Given this list of marker genes ADRA2C, GUCY2F, EEF1B2, EIF2S3, SAMHD1 (SAM and HD domain containing deoxynucleoside triphosphate triphosphohydrolase 1), RABGEF1, ARL17B, MON1A, TIAM1, GFM1, DEF6, EHD1, DIRAS1, SEPHS1, RASGRP1 (NCBI Gene Id 10125), RIT1, EIF2B2, TUBE1, TUBA3C, RAB17, MOCS1, ARL13A, PSD2, TUBB4B, NGB, DNAJC27, P2RY12, GNA13, ECT2, TUBA1C, PIP4K2B, RIC1, GUCY2C, CYTH1, TUBB2A, GIMAP1, PRKG2, ARL3 (NCBI Gene Id 403), TBC1D10A, MCF2L, ARHGEF10, PDE11A, CCDC88C, ABR, RAB1C, EHD3, VAV3, RASL10A, PDE6H, IFT27 (intraflagellar transport 27), GUCY2D, TRIM23, EHD4, ARHGEF37, SEPTIN9, IFT22, PLEKHG5, GRIPAP1, DENND5B, TIAM2, ARHGEF18, RAB6B, RAB37, SEPTIN5, LRRK2, RAB3IL1, ARHGEF6, RAPGEF4, SEPTIN4, FGD6, DRG1, ARHGEF40, RAP2C, ATL1, RASEF, TUBB3, GNAI2, ARF3, RABL2B, RAB5A, SMCR8, GDI1, RABL3, GBP4, RAB12, TUBA3E, FRMD7, RAB3IP, NPR2, DENND2B, CNGB1, CNGA1, DNM1P34, PLCG1, CRACR2A, NUDT2, DOCK11, ARHGEF7, PCK1, SPAG1, HHAT, TUBA1A, DNM1L, PLEKHG1, SUCLG2, GCH1 (NCBI Gene Id 93984), RAB34, RAPGEF1, DENND6A, AKAP13, DOCK3, RERGL (NCBI Gene Id 79785), SOS2, RAP2A, FGD1, ARHGDIG, ALS2CL, NME2, PDE6G, HERC2, GAPVD1, ITSN2, GPN3, RAB41, RAB23, SESN2, FKBP4, ARL2, GTPBP8, DENND11, RTCB, SAR1B, GTPBP1, RAB22A, GMPPB, AGAP2, RAB25, RASGEF1A, RGL1, RABIF, ADRA2A, AGAP1 (ArfGAP with GTPase domain, ankyrin repeat and PH domain 1), LAMTOR1, LRRK1, TBXA2R, NMUR2, SRL, RRAGB, GDI2, SEPTIN11, DEPTOR, ARL6, RAP2B, ITGB1BP1, ARL14, GNL3, RAB5C, HERC1, RAN, RHOB, RAB14, SPATA13, RAB40AL (NCBI Gene Id 548640), ZNG1B, DENND6B, RHOU (ras homolog family member U), RAB33B, CNGA4, GDPGP1, GUCY1A1, RASGEF1C, RTKN, RAB3D, RAPGEF3, PCP2, RND3, TGM2, GNL3L, MIEF1, NUCB2, RAB1A, PDE5A, FARP2, RAB30, RRAD, HPS4, GNA14, BCR, TUBG2, RAB36, KRAS, RHOH, ARHGEF4, ZNG1A, RGL4, EIF2B3 (eukaryotic translation initiation factor 2B subunit gamma), GPN1, IQSEC1, MRAS, PSD, EPS8L3, RAB33A, ARHGEF9, GBP6, ACSM5, RASL12, ZNG1E, RIC8A, EEF1A2, RABL2A, ARL5A, RAB11B, RAB28, GNAS, RIGI, RAB3GAP2, NOLC1, DAP3, URGCP, RGS14, TUBG1, ARFIP2, DAPK1, RHOT1, RERG, RGP1, RASGRF2, LAMTOR5, RRAS, IRGQ, PREX2, SOS1, GEM, SH3BP4, GIMD1 (NCBI Gene Id 100507096), RAB4B, SEPTIN7, PTGIR, PSD3, ARFRP1, DOCK10, RHOT2, ADSS2 (adenylosuccinate synthase 2), EIF2B5, ARHGEF5, AGAP3, MX1, MYCBP2, ATL3, STING1, IQSEC2, RAP1BL, RCC1, GUCY1A2, DENND3, GNAT1, GNAQ, RAB24, EGF (NCBI Gene Id 1950), RHOF, RAB6D, MFN1, CYTH4, ARF1, PDE2A, GIMAP8, RALB, SEPTIN10, GIMAP7, RCC2, KNDC1, RAB7B, RAB39A, RASL10B, EHD2, PLEKHG3, GTPBP3, UCP1, MTG2, GIMAP5, GBP2, TUBAL3, MFHAS1, DENND1B, TUBB1, RHOQ, MX2, RINL, ARF6, RANBP1, SRPRB, MCF2, WDR41, ARHGEF1, GNA12, EEF1D, VAV2, RASD1, FGD4, REM2, TUBB8, PCK2, PRKG1, RAB40A, MAB21L1, RPGR, NKIRAS2, DOCK5, DOCK8 (dedicator of cytokinesis 8), RHEB, DENND4C, DENND2A (DENN domain containing 2A), PDE6C, TSR1, ARHGEF33 (Rho guanine nucleotide exchange factor 33), LSG1, RAB26, RAB8A, RAP1A, DENND1C, HPS1, RASD2, RALGPS1, ARL13B, EEF1A1P5, ARHGAP35, CNGA2, GLUD1, FARP1, RRAGC, DYNC1LI1, GUF1, IRGC (immunity related GTPase cinema), OPA1, RAB3A, ARF4, TUBA8, GNL1, ELMO1, GBF1, DIRAS2, ARHGEF38, TUBA3D, RNGTT, FPGT, TUBA4A, ARL15 (NCBI Gene Id 54622), RHEBL1, PSD4, RAC2, RAB21, PREX1, RRAGA, ARL5B, ZNG1C, RAB2B, DENND4B, PLEKHG4, ARL4D, FGD5 (NCBI Gene Id 152273), RAB2A, SLC38A9, MTIF2, ERAS, GLUD2, RAB5B, THG1L, CHML, ARHGEF26, EEF2, RAB32, GTPBP10, SH3BP5L, RAB9B, RAB7A, SEPTIN8, RAC1, KIAA1755, SEPTIN14, PLCE1, RAB15, RALA, RAB20, DENND1A (DENN domain containing 1A, NCBI Gene Id 79878), ARHGEF28, RGL2, RIN3, RASGRP4, GTPBP4, RAB27A, RAB27B, CNGB3, EIF2B1 (NCBI Gene Id 1967), SH2D3A, RAB3GAP1, ERAL1, GNA15 (G protein subunit alpha 15), GTPBP2, LAMTOR3, DOCK7, ITSN1, RAB31, RAB6C, SERGEF, RND2, TUBB4A, GUCY1B1, GIMAP2, SBF1, ARL1, RANBP17, GBP7, EIF2B4, RAB11A, SLC19A1, RALGPS2, RASL11B, ANKRD27, SRP54, DENND5A, CPLANE2, ARHGEF16, RHOC, SEC61B, RAC3, DRG2, RAB39B (NCBI Gene Id 7489), CYTH2, CYTH3, IQSEC3, OLA1, NUGGC, SRPRA, VAV1, GVINP1, RAB8B, ARHGEF10L, KALRN, EIF5B, RASGRF1, ZNG1F, PLEKHG6, FGD3, ATL2, RASGRP2, SAR1A, LAMTOR4, LAMTOR2, RAB1B, GNL2, RAB40B, RASGEF1B, RAB6A, EEF1A1, GTPBP6, ARHGDIA (Rho GDP dissociation inhibitor alpha), RHOBTB2, ARL5C, ARHGEF2, MCF2L2, CNGA3, TRIO, ARL4C, EFTUD2, GSPT1, ARHGEF11, VPS9D1, ARL11, RGL3, RAB40C, RIN2, RAB9A, ECT2L (NCBI Gene Id 387075), ANXA6, RNF112, ADSS1, PLEKHG4B, RAB3C, RABL6, RHOG, ARL16, GCGR, RAPGEF2, GBP5, TUBB, SEPTIN2, CDC42, PLCD4, RIN1, GPSM1 (NCBI Gene Id 94330), ARHGDIB, BCAR3, NGEF, ALS2, SEPTIN12, RAP1B, GBP1, GIMAP6, CHM, TUBA4B, GNAT3, RANGRF (NCBI Gene Id 51536), TUBB6, DOCK2, MFN2, DNMBP, ARFGEF1, RRAS2, RAPGEF6, ARL8B, EFL1, RCC1L, SEPTIN3, RAB29, DENND2C, RAB38, DOCK9, GSPT2, ARHGEF39, DIRAS3, OBSCN, RHOV (NCBI Gene Id 171177), SH2D3C, ARFGEF3, DIS3, SEPTIN6, RIT2, NUCB1, GNAI1, ARHGEF19, DOCK1, CCDC88A, EEFSEC, RAB42 (NCBI Gene Id 115273), UPRT, CCZ1, CGAS, UCP2, TUBB8B, MMAA, PDE10A, RASL11A, NPR1, RAB43, RHOA, TUBD1 (tubulin delta 1), SCG5, GPSM2, ARHGEF12, SBF2, RCBTB2, NRAS, DNM1, TAGAP, PREB, GPN2, NKIRAS1, GIMAP4, ARL9, NET1, RAB3B, DENND4A, GBP3, ARL4A, IRGM (NCBI Gene Id 345611), AK3, REM1, NOA1, HRAS, RIC8B, TUBA1B, GFM2 (GTP dependent ribosome recycling factor mitochondrial 2), RP2, ARF5, BMS1 (NCBI Gene Id 9790), RANBP10, RHOD, GNAI3, EIF5 (NCBI Gene Id 1983), RALGDS, MADD, DENND10, DOCK4, RAPGEFL1, ACSM6, C9orf72, SH3BP5, RAB19, RAB10, DOCK6, ARHGEF15, TUBB2B, RAB18, RAP1GDS1, GNA11, MTG1, RHOJ, GNAO1, HBS1L, LANCL2, ACSM1, FGD2, PLEKHG2, EPS8L1, GNAT2, SWAP70, ARHGEF25, ARHGEF3, RAB13, RND1, ARL10, ARHGEF17, GNAL, EPS8L2, RHOBTB1, RAB4A, AK4 (adenylate kinase 4), CIITA, PLEKHG7, RASGRP3, DNM2, RRAGD, NIN, FBXO8, RAPGEF5, EIF2S3B, RAB44, HSP90AA1 (NCBI Gene Id 89272), MPPED2, NME1, DENND2D, GNAZ, INSR, DNM3, TUFM, SEPTIN1, ARFGEF2, RAB35, ARL8A, here is a description of the gene set: species: Homo sapiens Human Gene Set: GOMF_GUANYL_NUCLEOTIDE_BINDING Binding to a guanyl nucleotide, consisting of guanosine esterified with (ortho)phosphate.